The following is a description of a gene set: Mouse Gene Set: GOBP_MAMMARY_GLAND_DEVELOPMENT species: Mus musculus The process whose specific outcome is the progression of the mammary gland over time, from its formation to the mature structure. The mammary gland is a large compound sebaceous gland that in female mammals is modified to secrete milk. Its development starts with the formation of the mammary line and ends as the mature gland cycles between nursing and weaning stages., and this is the list of marker genes: Arhgap5, Rtn4, Prl2c3, Prl7c1, Mst1, Csmd1, Pml, Capn1, Irs1, Fgfr2, Prl7d1, Wnt2, Cdo1, Ccnd1, Prl2c5, Tgfbr2, Prl7a1, Prl3d2, Foxf1, Wnt5a, Nrg3, Pax3, Gsdma3, Prl3c1, Hoxd9, Prl2b1, Brca2, Robo1, Stat5a, Csn2, Hoxa9, Rplp0, Cebpb, Prl3b1, Deaf1, Prl8a2, Kalrn, Sostdc1, Prl2c2, Hk2, Wnt4, Aprt, Areg, Id2, Zfp703, Btrc, Pgr, Prl2a1, Tbx3, Lrp5, Bmp4, Fasn, Prl3d1, Msx1, Atp2c2, Etv5, Tnfsf11, Slc29a1, Sox9, Cav1, Irf6, mt-Co2, Elf3, Ptch1, Atp2b2, Kdm5b, Pinc, Perp, Neurl1a, Smo, Nme1, Arhgap35, Prl7b1, Agap2, Prl3a1, Ncoa1, Fgf2, Rxfp1, Hoxb9, Med1, Chuk, Csf1, Stat5b, Gli3, Bcl2l11, Ddr1, Iqgap3, Oas2, Gja1, Tgfb1, Cyp19a1, Nfkb1, Tgfb3, Cav3, Src, Cdkn2a (cyclin dependent kinase inhibitor 2A), Igf1 (insulin-like growth factor 1), Prl (prolactin), Nr3c1, Vdr, Ncoa3, Prl8a9, Ccl11, Lrp6, Igfbp5, Erbb4, Tph1 (NCBI Gene Id 21990), Hif1a, Ar, Elf5, Ghrhr, Prl8a8, Phb2, Hoxa5, Rreb1, Etv4, Igf1r, Ccl2, Vegfa, Eif2ak3, Stat6, Cad, Scrib, Prl7a2, Irs2, Lef1, Fgf10, Gpat4 (glycerol-3-phosphate acyltransferase 4), Gpx1, Prl2c1, Esr1, Zfp157, Bsx, Atp7b, Umps, Csn3, Foxb1, Tbx2, Tfap2c, Xbp1, Zbtb7b (zinc finger and BTB domain containing 7B), Mapk1, Pthlh, Slc12a2, Wnt3, Prl8a1, Prl4a1, Rln1, Xdh, Prl8a6, Usf2, Bax, Gata3, Prl3d3, Wnt3a, Slit2, Epha2, Lats1, Prl5a1, Zfas1, Egf, Socs2, Prl6a1, Gli2, Itga2, Jak2, Slc6a3, Msx2, Notch4, Tnfrsf11a, Tgfa, Uprt, Orai1, Creb1, Lbh, Pygo2, Ntn1, Prlr, Abcb1a